Given this list of marker genes PENK, SOX11, FOXP1, PRKCH, ARF3, C4A, PDYN, TXNRD1, CADM1, PTPRM, CPNE6, ETS2, PBX3, NNAT, GEMIN5, WDR6, ATP11A, TEF, PLAGL1, CRY1, AGO2, COL6A1, PNCK, LDB2 (NCBI Gene Id 9079), PDRG1, HAP1, ACTB, HES5, KCNA4, MAN1A1, ZBTB20, PLA2G12A, PER2, ARGLU1, PKP2, ADISSP, TSC22D1, AMY2B (NCBI Gene Id 280), POU3F4, SPIN1, DYNLT1, DKK3, PDXK, PTCH1, AQR (NCBI Gene Id 9716), EPB41, TRHR, GRB2, SIX3, AASS, DHCR7, SKP1, IQGAP2, DOC2B, RBCK1, CCDC88A (coiled-coil domain containing 88A), here is a description of the gene set: DeltaFosB (a truncated form of FosB) and CREB (cAMP response element binding protein) are transcription factors induced in the brain's reward pathways after chronic exposure to drugs of abuse. However, their mechanisms of action and the genes they regulate remain unclear. Using microarray analysis in the nucleus accumbens of inducible transgenic mice, we found that CREB and a dominant-negative CREB have opposite effects on gene expression, as do prolonged expression of DeltaFosB and the activator protein-1 (AP-1) antagonist DeltacJun. However, unlike CREB, short-term and prolonged DeltaFosB induction had opposing effects on gene expression. Gene expression induced by short-term DeltaFosB and by CREB was strikingly similar, and both reduced the rewarding effects of cocaine, whereas prolonged DeltaFosB expression increased drug reward. Gene expression after a short cocaine treatment was more dependent on CREB, whereas gene expression after a longer cocaine treatment became increasingly DeltaFosB dependent. These findings help define the molecular functions of CREB and DeltaFosB and identify clusters of genes that contribute to cocaine addiction. from publication McClung CA, Nestler EJ (PMID 14566342) studied in species Mus musculus Genes down-regulated in the nucleus accumbens (a major reward center in the brain) 8 weeks after induction of CREB1 expression in a transgenic Tet-Off system. Human Gene Set: MCCLUNG_CREB1_TARGETS_DN